The following is a description of a gene set: species: Mus musculus Mouse Gene Set: GOCC_MRNA_CLEAVAGE_FACTOR_COMPLEX Any macromolecular complex involved in cleavage or polyadenylation of mRNA molecules., and this is the list of marker genes: Cpsf1, Pcf11, Fip1l1, Cstf3 (NCBI Gene Id 96986), Cstf2, Cpsf2, Cpsf7, Cstf1, Zc3h3, Cpsf6, Csnk1a1, Cpsf4, Wdr33, Scaf8, Cpsf4l, Cpsf3, Tut1, Marveld3, Sympk, Cstf2t, Nudt21, Clp1, Ssu72, Pip5k1a